The following is a description of a gene set: Mouse Gene Set: GOBP_REGULATION_OF_TRANSLATION_INITIATION_IN_RESPONSE_TO_ENDOPLASMIC_RETICULUM_STRESS studied in species Mus musculus Any process that modulates the frequency, rate or extent of translation initiation, as a result of endoplasmic reticulum stress., and this is the list of marker genes: Nck1, Eif2ak3, Dnajc3, Nck2, Tmed2, Eif2ak4